The following is a description of a gene set: studied in species Mus musculus Genes predicted to be targets of miRBase v22 microRNA mmu_miR_6926_5p in miRDB v6.0 with MirTarget v4 prediction scores > 80 (high confidence targets). Mouse Gene Set: MIR_6926_5P from publication Chen Y, Wang X (PMID 31504780), and this is the list of marker genes: Pptc7, Vsig10, Mrgprb2, Metrnl, Cyp2s1, Zswim4, Exph5, Semp2l1, Plxnb3, Tomm70a, Prr14l, Rap1gds1, Brcc3, Mras, Nsun6, Slc35f1, Klhdc7a, Fads1, Creg2, Mllt10, Hpcal4, Adgrf2, Prkacb, Senp2, Cct6a, Nphs2, Col6a1 (collagen, type VI, alpha 1), Pask, Lyg1, Oscar, Itga5, Nipbl, Bcl10, Ap3b2, Tufm, Hspb7, 6430550D23Rik, Trim16, Tab2 (TGF-beta activated kinase 1/MAP3K7 binding protein 2), Ahsg, Pex14, Zfp175, Acly, Arhgap32, Asb15, Vps13b, Mllt6, Tcta, Stx5a, Skap1, Szrd1, Mecp2, Hsbp1l1, Casp2 (NCBI Gene Id 12366), Dhdh, Grin1, Orai1, Heca, Kcnj4, Rffl, Nme2, Ankib1, Zfp174, Phaf1, Eri2, Col19a1, Kynu, Rnf157, Cdc14b, Stxbp2, Emilin3, Syt12, Ppp1r10, Orc2, Arc, Ica1l, Gprin3, Cmtm8, Spata13, Cd3d, Hs3st3b1, Zfp280d, Xlr, Sox14, Alas1, Cdk18 (NCBI Gene Id 98233), St8sia6, Brat1, Pogz, Slc49a4, Ctnnd1, Rragc, Slc27a1, Plcxd3, Setbp1